Given this list of marker genes Tns3, Cdh13, Gm19261, Anxa7, 5031434O11Rik, Utp25, Bnc1, Cyp2b23, Dclre1a, Lancl1, Arhgap45, Tmem140, Pcdhgc5, Spag5, Nemp2, Gm10729, Fam193b, E2f2, Tsen54, P4ha2, Dnai2, Tgif1, Lars1, Catsper2, Fanca, Gm10531, P3r3urf, S100pbp, Gys2, Tex14, Fam117a, Iqce, D030068K23Rik (RIKEN cDNA D030068K23 gene), Gm13594, Ly6g6f, Lbhd1, Chd7, Gm15039 (NCBI Gene Id 666288), Fam98c, Nhlrc2, Elp6 (elongator acetyltransferase complex subunit 6), Gabra2, 1700101I11Rik, Lgals4, Zfp207, Plcd4, Ino80dos, Usp1, Trp53rka, Gne, Trim36, Chrna9 (cholinergic receptor, nicotinic, alpha polypeptide 9), Kat2b, Mdk, Gm23483, Eif2d, Lactb2, Wdfy3, Kazald1, Pole2, Rad54l2, Agap3 (ArfGAP with GTPase domain, ankyrin repeat and PH domain 3), Rfx7, Zwilch, Zbtb48, Gm25608, Sh3bgr, Zfp27, Gm25224, Ext1, Btbd18, Mir376a, Kash5, Eda2r, Enkur, Gm8883, C330002G04Rik, Kif3a, Uvrag, Psph, Hs3st3a1, Abcc3, Mir7668, Plekhb1, Gm8973, Ppp2r5c, Cep85, Gm9887, Gm13690, Fignl1, Marchf2, Rbm47, Eif3d, Atg16l1, Mir6365, Dst, Thap6, Xpnpep1 (NCBI Gene Id 320447), Gm22272, Matk, Gm16096, Trp53i13, Fkbp4, Cars1, Rps12-ps26, Gm16833, Ncoa4, Meox1, Kbtbd7, Dpp4, Ehmt2, Kdm5c, Inpp5b, Adig, Mthfsd, Fastkd5, Adam8, Atp8b3, Tsga13, Gm12608, Cpsf1, Zbtb25, 1700022A21Rik, 4932412D23Rik, Ywhag, Cngb1, Vps72, Jak1, Senp6, Usp14, Gm12189, Defb40, Gm12803, Pde4dip, Mto1, Ighg1, Pde4d, Mrpl9, Foxh1, Slc39a2, Pate2, Nadsyn1, Rad51c, Ppip5k1, Zfp747l1, Gm7094, Gm13544, Vps8, Slc26a3, Pcsk6, Zfp7 (zinc finger protein 7), Impdh1, Spcs1, Gm19705, Klf8, 1700104B16Rik, Chchd10 (NCBI Gene Id 216112), Tcea2, Gm15651, Tnfrsf1a, Nectin3, Idh2, Tcf7, Gtf2e2, Uggt1, Gm12492, Med18, Gltpd2, Babam2, Mkln1, Nts, Mir654, Ebf2, Klf1, 1110038B12Rik, Gm24592, Tm4sf5, Tcp1, Mxra8, Vpreb1a, Iqsec1, Lama5, 1700008O03Rik, Celf3, Srd5a3, Synj2, Atp2c1, Rph3a, Il34, Naa25, Ccer2, Arl15, Tmco2, Nova1, Csn1s2b, 1700023H06Rik, Lbr, Golt1b, Snord52 (NCBI Gene Id 100217427), H2aj (H2J.A histone), Pla2g10, Psma3, Eddm13 (epididymal protein 13), Slu7, Mak16, Gm10138, Sp1, Stk38l, Hoxa3, Or2c1, Synpo2l, Platr27, Gm5185, Cpsf6, 4930451E10Rik, Atp5f1a, Mir152 (microRNA 152), Dis3l, Naprt, Galnt17 (NCBI Gene Id 94250), Park7, Gm24068, Gm26207, Foxk2, Rnf17, Btbd19, Acad11, Tanc1, Rnf135, Gm12620, Ifna13, Tgoln1, Zfp715, Gm3830, Map4, Niban3, Lhfpl4, Gm17806, Vmn1r192, Nr3c2, Rbp7, Gnpat, A930001C03Rik (NCBI Gene Id 319314), Ccdc28a, Nicn1, Ddx47, Usf2, Pttg1ip, Eif1ad, Acsbg3, Hoxa7, Tamm41, Serpine2, Gm8398, Ppp1r10, Foxc1, Tmc4, Bcar3, Gfer, Zfp866, Zfp975, Copz2, Esrp1, Cacna2d4, Gm5258, Limch1, Ddx23, Rhot1, Tonsl, Bmal1, Lgmn, Ccdc9, Rtl5, Ppp1r16a, Lrrc23, Mirlet7g, Tor1aip1, Hspa4, Tbc1d14, Capns1, Tfap4, Magi1, Hcls1, Itgb5, Gm12924, Chrd, Tmem102, Tbc1d10b, Ube2i, H2-M5, Rbm20, Zfp64, Mdfic2, Gm26885, Hdac4, Best4-ps, Znfx1, Zbtb43, Dhps, Vgll4, Gm29718, Fxr2, Rragc, Pisd-ps1, Ggt7, Ltbp3, Rnf4, Syce3, Kntc1, Spindoc, Zfp763, Rgs12, Gm28874 (predicted gene 28874), Gm26176 (predicted gene, 26176), Bin2, Pga5, Tyw1, Gm15895, Gm16084, Stt3b, Tgfbr3, Pomgnt1, Nipbl, AU016765, Crispld2, Gcnt7, Ogt, Egr4, St3gal6, Slc18a3, Slc22a7, Pdlim5, Acot3, Gm24888, Adh1, Golga5, Celf2, Susd6, Brwd1, Gga2, Gm12980, B4galt7, Mfap1b, Rab27a, Mepce, Gm6285, Tango2, Gal3st1, Gm26473, Setd7, Foxm1, Ephb6, Gm4535, Ammecr1, Zfp512b, Anp32e, Kpna2, Stox2, Stk32b, Misp3, Sp2, Gm25261, Helz2, Ube4bos3, Gm6096 (NCBI Gene Id 636444), Ehbp1, 2810407A14Rik, Gm24878, Tnfaip2, Plcxd2, Lag3, Mgst2, Pparg, Lonrf2, Gm25482, Art1, Flad1, Tigd4, Pdlim2, Gm10069, Wars2, Zfp319, Sarm1, Hif1a, Acaa1b, Zfp788, Mutyh, Trmt9b, Ptbp1 (NCBI Gene Id 19205), Setd1a, Gm16283, Tor1aip2, Cp, Mrm2, Exoc6b, Sergef, 1700129L04Rik, Ebna1bp2, Nbeal2, Morc4, Nhsl2, A230083N12Rik, 1700019G24Rik, Meg3, Vamp1, St14, Serpinb6e, Gm10649, Cers6, Gm15707, Smagp, Cdkn1a, Agtrap (NCBI Gene Id 74834), Dot1l, Ica1l, Tagln2, Gm15610, Ctsa, Cyb5r1, Phactr4, Lcn12 (lipocalin 12), Gm7733, Mir6981 (NCBI Gene Id 102466779), Arf4, Klhl18, Gm11475, Ankrd1, Fry, Plekha6, Tcf19, Aste1 (asteroid homolog 1), Cldn34c1, Snhg7os, Tulp3 (TUB like protein 3), Exosc2, Cblc, Lrriq1, Mir6367, Gm24665, Fgfr2, 4930402F06Rik, Gse1, Gm14162, Car7, Magohb, Rnf126, Gm11292, Ninj2, Ttf1, Gnl3, Ckap2, Mir8090, Rad54l, Zfp36l1, Scd4, Elp5, Spin1, Amigo1, Slc9b2, Plekhg1, Atf7ip (activating transcription factor 7 interacting protein), Gm16063, Dpep3, Csf1r, Galnt1, Map4k4, Scube3, Ankrd40, Atp5f1d, Irf3, Hnrnpr, Fbxo36, Tmem202 (transmembrane protein 202), Serpina10, Dcakd, Surf6, Gcn1, Lat2, Tekt5, Ercc2, Aebp2, Ptpn11, Usp46os2, Hsp90ab1, Pakap, Srrm1, Ing4, Ube2k, Rcbtb1, 9430015G10Rik, Prpf38b, Myo18a, Mroh1, Map3k5, Npr3, Ech1, Wfs1, Mccc1os, Kcnt2, Armcx1, Pf4, Tmem265, Fam216a, Ascl4, Snta1, Prrc2c, Gm12977, Kptn, Gm19815, Stpg3, Dnajb2, Slc1a2, Dnmt3a, Tmem242, Mmp19, Gpr35, Hexim2, Ifrd1, Ldha, Pou6f1 (POU domain, class 6, transcription factor 1), Gm14987, Gpr62, Gm16342, Lsamp, Timm13, Cnih1, Mbtps2, Zdhhc6, Gm4847, Cuedc1, Shank2, Kank1, Galt, 4931406C07Rik, Arhgap27os1, Gm2800, Cxxc4, Cnppd1 (NCBI Gene Id 98606), Cerk, Entpd8, Snx1, Gm28836, Mrm1, Znrf1, Mir142, Arih2, Pglyrp3, Rnaseh2a, Ccdc6, Morf4l1, Gm6736, Pick1, B3gat1, Gm26479, Map6, Plcl2, Fcf1, Yars1, Amz1, Gm25862, Cyp4a30-ps, 4933408N05Rik, Zmiz2, Parp11, Scrn2, Gm9630, Usb1, Tdrd9, Ushbp1, Coprs, Tubgcp3, Trip12, Uts2r, Lst1, Dlgap5, Pitpnm2, Tceanc2, Gm12057, P2rx3, Inpp5k, Ppp4r1, Trp53cor1, Ift122, Clasp1, Snx10, Uba52, Nim1k, Mbd5, Slitrk5, Rsph14, Or1a7-ps1, Ctbp2, Arhgdib, Palld, Vwf, Klhdc2, Got1l1, Aldoa, Uso1, Pik3r1, Ddb2, Polrmt, Cldn22, Zan (NCBI Gene Id 22635), Gm12740, Poc1a, Gm26211 (NCBI Gene Id 115485861), Gm23390, Mettl4-ps1, Ext2, Prss54, Atp7a, Epha10, Zfp212, Hoxa11, Nop58, 2500004C02Rik, S1pr4, Styk1, Septin9, Mrpl14, Glra2, Gm2990 (predicted gene 2990), Taf4, Gzmm, Sass6, Pdlim1, Rpl5, Cyp4a28-ps, Mir376b, Oser1, Vti1a, Dars2, Gm11198, Psma4, Rbm5, Dcaf6, Eef1a1, Mxd3 (Max dimerization protein 3), Uhrf1, Cfap251, En1, Plagl1, Thrap3, Rfwd3, Gatad2a, Taf1d, Rab43, 2310034O05Rik, Slc1a3, Top3b, Ttc39c, Chd8, Kdm5a, Pzp, Mir7664, Zbtb1, Mpz, Cfap96, Zbtb34, Pdcd6ip, Ddx20, Sinhcaf, Akr7a5, Mast1, Dhtkd1, Gm24461, Satb2, Gm23090, Adarb1, Scin (NCBI Gene Id 20259), Nek9, Thumpd3, Lingo4, Map2k1, Hsd11b1, Capn10, Dhcr7, Il17rd, Trpm1, Tsga10, Myo10, Supt7l, 1700109I08Rik, Serpinb11, Gm6633, Dkkl1, Ccsap, AI661453, Hapstr1, Gna11, Gabrr2, Kifbp, Mir142hg, 2900092N22Rik, Rabl6, Gm12333, Plcb2, Dsc1, Mrpl13, Mpi, Flvcr1, Atrip, Aatf, Kcnu1, Adat1, Cd9, Mvd, Mir770, Fat2, Psmd2, Rere, Rad51ap2, Gm10062, Spry4, Mpzl2, Ndfip2, Crybg2, Sfrp1, Slx4, Frmd5, Aars1, Kank3 (NCBI Gene Id 80880, KN motif and ankyrin repeat domains 3), Fam193a, Ppfia1, Cngb3, Cryl1, Nav2, 9930012K11Rik, Gm13529 (NCBI Gene Id 100041918), 1700071K01Rik, 1110028F18Rik, Smpd5, Gpr84, Pus1, Nadk2, Nme4, Zfp710, Babam1, Trap1, Src, Mir7075, Gm9496, Ssrp1, Arl2bp, Unc13a, Nfasc, Gm10123, Ppard (peroxisome proliferator activator receptor delta), Fam186b, Mrpl21, Hmgb1, Gm9599, Gpr107, Luc7l3, Itpa, Cdc42se2, Atxn3, G6pc3, C3ar1, Lhx4, Clcn7, Matcap1, Recql, Dazap1, Hoxa11os, Ly6g, Ino80d, Ssc4d, Clk4, Trim67, Ccdc63, Gm5915, Smim14, 2410002F23Rik, 1700001O22Rik, Chchd2-ps, 2010016I18Rik, Sertad2, Mir6924, Wdr95, Ralbp1, Il2ra, Atcay, Rigi, Gripap1, Ccndbp1, Gm13094, Dync1h1, Snu13, Gm26705, Gtf2a1, Dnajc17, Gatc, Armcx2, Mir1199, Gstp2, Gm23706, Pccb, Slc35a3, Rdm1, Gm4349, Extl1, Gm14210, Tspan17, Ltbp1, Srsf1, Gm6649, Pde8a, Car11, Lztr1, Myo15a, C230035I16Rik, Diaph1, Hkdc1, Abcf3, Lpcat1, Gm25438, Prickle4, Cbfb, Asxl1, Mrps12, Gm15032, Zfta, Tram1, Gm13338, Safb2, Gm11149, Stat5a, Slc7a11, Prkrip1, Fmn1, Sun1, Trim47, Carhsp1 (calcium regulated heat stable protein 1), Capza1 (capping actin protein of muscle Z-line subunit alpha 1), Ankrd60, Ppa2, Yju2, Atg13, Rhou, Gm26725, Mtbp, Runx2, A930032L01Rik, Ubap2, As3mt, Kcnip2 (Kv channel-interacting protein 2), Slc2a3, Rcor2, Tjp2, Caskin2, Lims1, Uba5, Zbtb8a, Eif2ak4, Mir376c, Mfn1, Vac14, Radx, Apom, Setdb2, Acsbg2, Slc38a8, Rfx2, Atosb (NCBI Gene Id 230088), Gm26049, Hrob, Dnajc11, Ctcf, Gm14303, Tent2 (NCBI Gene Id 218445), Pdia3, Gm11637, Neurl4, Degs2, Nos1, Crem, Tgfbr2, Ufsp2, Tsga10ip, Hars2, Guca1b, Mzf1, Cfap69, Slc25a38, Mybl2, Shmt1, Fau-ps2, Ccdc65, Mtif3, Hotairm1, Gm5436, Rbbp6, Mir3965, Pramel13, Gm49316, Xpnpep2, Eif5a, Faddos, Peg12 (NCBI Gene Id 27412), Smc3, Clec2d, Mgat5, Strn4, C030013C21Rik, Gm25184, Timp4, Ttc24, Mpc2, Prrg3, Ntpcr, Mdn1, Evl, Gm23382, Gpr157, Gm5507, Arrdc3, Adipor2, Gm5532, Arhgap26, Tal2, Zfp637, Acot11, Tmem53, Prss40, Dnaaf9, Dnajc13, Pmm1, Gm8022, Paqr8, Kcnv2, Hhip, Shox2, Glrx5, Jup, Pip4k2c, Nbr1 (NCBI Gene Id 17966), Pou2f2, Ptp4a1, Smtn, Ing3, Pygb, Ipo9, Fhip2b, Gm5251, Sestd1, Zbtb7a, Cnbd2, D030056L22Rik, Thnsl1 (threonine synthase-like 1 (bacterial)), Hyls1, Gpkow, Gm12125, Defb47, Bag5, Rex1bd, Mycbp2, Taf1c, Zcwpw2, Il4, Unc13b, Efna3, Mir17hg, Lamp5, Adhfe1, Sntb2, Sv2b, Gm26070 (NCBI Gene Id 115485848), Terf2, Zfp395, Gm24400, Ppfibp2, Smg7, Fcgr2b, Dlk1, Tpd52l2, Stx3, Piwil1, Plet1os, Man2a2, Acap1, Hsd3b7, Itpr2, Prss50, Akr1a1, Azi2, Kmt2d, Haus5, Ankrd44, Eif4e2, Gm11444, Gm15927, Gm12271, 2610206C17Rik, Gm14095, Slitrk3, Zmynd12, Atpaf1, Rcor3, Slc9a8, Ssbp4 (single stranded DNA binding protein 4), Reps1, Gm15821, Tatdn2, Gm12828, Cd164, Naa16, Sema4g, Gipc2, Maf, Tmem129, Ift140, Lrriq4, Tcf4, Zfp438, Stk19, Sec14l5 (SEC14-like lipid binding 5), Platr22, Pcmtd2, Bmt2, Bcl6, Pdpr, Ptges3, Mlxip, Ubald1, Samd1, Gpn3, Ccdc14, 1500012K07Rik, Inpp5f, Armh3, Ep400, Pkd2l1, Gm23273 (NCBI Gene Id 115486355), 9330162B11Rik (RIKEN cDNA 9330162B11 gene), 4930517L18Rik, Sox4, Atp23, Cradd, Eif3k, Srpk1, Shf, Fh1 (NCBI Gene Id 14194), Cltc (NCBI Gene Id 97762), Phlpp2, Snora17, Rsrc2, Usp21, Nudt1, Rrp7a, Rogdi, Gm14111, Ube2f, Gnai2, Gm11191, Dpp6 (NCBI Gene Id 51817), Zbbx, Cfap74, Ralgapb, Atrnl1, 1700029H14Rik, Jakmip1, Gm23116, Rps6ka1, Slc38a10, Rell1, Mob4, Mir3085, Tbx3os1, Zfp563, Gm14010, Sec31a, Gamt, Atp6v1e1, Sapcd2, Agpat2, Cep95, Slc25a19, Fndc7, Rbl2, Triap1, Efhc2, Gm6365, Kcnh8 (NCBI Gene Id 211468), Tsfm (NCBI Gene Id 77321), Bcas1, Nr0b2, Aida, here is a description of the gene set: Mouse Gene Set: ZFP429_TARGET_GENES studied in species Mus musculus from publication Yevshin I, Sharipov R, Kolmykov S, Kondrakhin Y, Kolpakov F (PMID 30445619)